The following is a description of a gene set: Genes enriched in oligodendrocytes in the adult mouse brain identified through correlation-based searches seeded with the oligodendrocyte cell-type specific gene expression patterns. Mouse Gene Set: LEIN_OLIGODENDROCYTE_MARKERS Molecular approaches to understanding the functional circuitry of the nervous system promise new insights into the relationship between genes, brain and behaviour. The cellular diversity of the brain necessitates a cellular resolution approach towards understanding the functional genomics of the nervous system. We describe here an anatomically comprehensive digital atlas containing the expression patterns of approximately genes in the adult mouse brain. Data were generated using automated high-throughput procedures for in situ hybridization and data acquisition, and are publicly accessible online. Newly developed image-based informatics tools allow global genome-scale structural analysis and cross-correlation, as well as identification of regionally enriched genes. Unbiased fine-resolution analysis has identified highly specific cellular markers as well as extensive evidence of cellular heterogeneity not evident in classical neuroanatomical atlases. This highly standardized atlas provides an open, primary data resource for a wide variety of further studies concerning brain organization and function. from publication Lein ES, Hawrylycz MJ, Ao N, Ayres M, Bensinger A, Bernard A, Boe AF, Boguski MS, Brockway KS, Byrnes EJ, Chen L, Chen L, Chen TM, Chin MC, Chong J, Crook BE, Czaplinska A, Dang CN, Datta S, Dee NR, Desaki AL, Desta T, Diep E, Dolbeare TA, Donelan MJ, Dong HW, Dougherty JG, Duncan BJ, Ebbert AJ, Eichele G, Estin LK, Faber C, Facer BA, Fields R, Fischer SR, Fliss TP, Frensley C, Gates SN, Glattfelder KJ, Halverson KR, Hart MR, Hohmann JG, Howell MP, Jeung DP, Johnson RA, Karr PT, Kawal R, Kidney JM, Knapik RH, Kuan CL, Lake JH, Laramee AR, Larsen KD, Lau C, Lemon TA, Liang AJ, Liu Y, Luong LT, Michaels J, Morgan JJ, Morgan RJ, Mortrud MT, Mosqueda NF, Ng LL, Ng R, Orta GJ, Overly CC, Pak TH, Parry SE, Pathak SD, Pearson OC, Puchalski RB, Riley ZL, Rockett HR, Rowland SA, Royall JJ, Ruiz MJ, Sarno NR, Schaffnit K, Shapovalova NV, Sivisay T, Slaughterbeck CR, Smith SC, Smith KA, Smith BI, Sodt AJ, Stewart NN, Stumpf KR, Sunkin SM, Sutram M, Tam A, Teemer CD, Thaller C, Thompson CL, Varnam LR, Visel A, Whitlock RM, Wohnoutka PE, Wolkey CK, Wong VY, Wood M, Yaylaoglu MB, Young RC, Youngstrom BL, Yuan XF, Zhang B, Zwingman TA, Jones AR (PMID 17151600) studied in species Mus musculus, and this is the list of marker genes: Ccp110, Fabp5, Cryab, Plekhb1, Hcn2 (hyperpolarization-activated, cyclic nucleotide-gated K+ 2), Tmem88b, Cnp, Olig1, Mal, Selenop, Abca2, Cntn2, Opalin (NCBI Gene Id 226115), Ptgds, Qdpr, Plekhg3, Syt11, Taldo1, Gpr37, Nrbp2, Pcyt2, Anln, Scd3, Gjb1, Serinc5, Sgk1, Gsn, Hmgcs1, Serpinb1a, Aatk, Tspan2, Septin4 (septin 4), Cers2, Apod, Olig2, Eef2, Tppp3, Daam2 (NCBI Gene Id 76441), Mcam, Car2 (NCBI Gene Id 99551), Slc44a1, Sox10, Cd81, Tmbim6, Fa2h, Slc48a1, Serpinb1c, Ermn, Mbp, Gltp, Scd2, Qki, S100a16, Frmd4b, Myrf, Pex2, Ttyh2, Rnf13, Npc1, Mtrr, Gje1, Mog, Ugt8a, Arhgef10, Gatm, Csrp1, Arrdc3, Ndrg1, Map2k6, Omg, Mag, Actc1, Wscd1, Pacs2, Tmem63a, Clic4, S1pr5, Mobp